The following is a description of a gene set: Human Gene Set: MIR6873_3P from publication Chen Y, Wang X (PMID 31504780) Genes predicted to be targets of miRBase v22 microRNA hsa-miR-6873-3p in miRDB v6.0 with MirTarget v4 prediction scores > 80 (high confidence targets). studied in species Homo sapiens, and this is the list of marker genes: CD160, ZNF91, GK5, NRN1 (neuritin 1), NPAT, PHF21A, ZNF439, SLAIN1 (SLAIN motif family member 1), RPP30, SEPTIN8, KCNK17, ZDHHC21, ZSCAN22, ZNF280B, SP100, ZNF268, MRO, ZNF676, SETD9, CTTNBP2NL, KRIT1, RIN2, ACSM2A, CBS, BTRC, MCM10, ZNF728, SRP19, PPRC1, SYNPO2, SOX5, CDC42BPA, SERTM1, SLC22A15, WBP1L (WW domain binding protein 1 like), SYS1, SORBS1, SLC25A20, VWC2, ADCYAP1, ATP2B2, RNF213, LRIG3, ZNF594, TLE5, GPATCH11, RNF169, ANOS1, ZNF778, PITPNM3, FBXL16, MAN2A1, IL5RA, STON2, DTNA, CD300E, SNRK, NLK, DCUN1D5, PDK3, ZNF100 (NCBI Gene Id 7653), CYTH4 (NCBI Gene Id 29776), ZNF708, ZNF302, BMAL1, ZNF195, SLC5A12, KCNK6, FAM131B, VCF1, POFUT1, RORA (NCBI Gene Id 6095), LYSMD3, VIP, CACNG8, ZNF559-ZNF177, ZNF107, PROM1, PPP6R1, B3GLCT, INHBB, ANTXR2, RREB1, DENND4A, ZNF426, TRMT12, METTL8, SMIM8, PDE7B, AUTS2, APBA1, USP32, ZNF761, ZNF468, ZNF544, VAT1L, KCNS1, EYA3, ZNF578, PGF, RABEP1, MAP4K2, SPOP, ZNF90, MBNL3, MAGI3, SHOX, HRH1, RPRD1A, RIMKLB, CTSO (NCBI Gene Id 1519), ZDHHC22, CDKN2AIP, PAPPA, ZNF716, CCDC178, PURA, EFCC1, MAFG, ZNF772, GPC6, ALKBH8, ATXN1, ASCL1, RDX, GRAMD1B, DPF3, LGSN, COPS2, ZNF596, GDAP1L1, ZBTB7A, ZNF701, RTKN2, VGLL3, ONECUT2, STAT5A, C11orf87, ZNF816, ARF6, ZNF208, CFAP97D1, GPBP1L1, POU2F2, TVP23C, TRPC5OS, MSI2, TBL1X, TAF11, DNAAF11, TMEM245, DPYD, HLA-DOA, PRPF38B, DENND6A, HOXC6, MAP3K2, LZIC, CNIH3 (NCBI Gene Id 149111), MAPK14, ZNF514, FASLG, TFAP2E, ZBTB17, IL17RA, MZT1, HMGCS2 (NCBI Gene Id 3158), SPRY3, ACER3, LONRF3, ZNF493, VANGL1, CDK12, WDR45B, NEIL2, ZBTB40, ARHGAP42, WWC1, MC2R, ZNF813, WSCD2, TMCO1, ADPRH, PPP2R5B, ZFP90, ADRB2, ACSM2B, WNT8A, GABRB1, APELA, SLC7A11, BHLHE22, LENG8, KIAA1549L, RBFOX2, MDM2, CPLX2, SBNO1, FAF2, PLCL1, ADRA1A, SMIM21, PLA2G7, LRRC10B, PSD3, CDH19, ELAVL3, SANBR, ILDR2, EMX2, PDGFA, PLXNA1, NELL1, CALU, RAPH1, ZNF711, AGAP1, RNF148, NHERF2, USP6NL, LACC1, SLC12A2, PRDM2, CARMIL1, MBNL1, HNMT, PRDM10, KIF4A, ZNF655, SNCA, SF1, ZNF135, TM9SF3, ARHGEF3, SIGLEC15, CCL16, PLEKHA6, ZNF28, MAP1B, SCN2B, NLGN4X, SYNJ2BP, CHMP7, TBC1D19, FANCC, REP15, MOB1B, USP10, PLGLB1, ZNRF3, ENPP1, ZNF611, PARD3B, ZNF99, EP300, HOXC5, PARM1, DDX19B, GPR161, THSD7B, PGM2L1, ELAVL4, NEURL1B, PAGR1, GPATCH2L, ZNF610, FRMD3, BBX, MSL1, TBX5, STK17A, SLC10A3, PCP4, SBF1, MID1, SLC5A3 (NCBI Gene Id 6526), KAZALD1, AQP4, ZNF117, KIF21A, OVOL2, SELENOS, CD86, DISC1, C22orf46P, MTPN, GLCE, WDR27, SOST, EVC, TLX2, CADM2, IFIT2, BNC2, PCSK4, ZNF138, ST8SIA1, POU3F2, ENSG00000274276, RNF185, TBL1XR1, SLC30A7, CC2D2B, MAFK, ARL15, ASAH2B, BCL11A, TMEM135, DES, GRID1, ESRRG, ZNF670, MYLK, ZNF844 (zinc finger protein 844), ZNF808, PEG10, ZNF124, CD44, NTRK2, SV2C, EPB41L3, MARK1, LPP, ZCCHC8, NIPA1, ZNF415, ZNF557 (NCBI Gene Id 79230), ZDHHC9, AGPAT1, RTN4RL1, IKBIP, TBX3, SGMS1, TNS1, SMARCA4, TNFRSF13B, GPR176, FRMPD4, KCNJ3, TLE4 (NCBI Gene Id 7091, TLE family member 4, transcriptional corepressor), HDAC8, ZNF562, MEX3A, RANBP3L, CELF4, SEMA3A, ZNF721, ZNF136, ITGA4, CDNF, UNC13A, TMEM178B, LSAMP, ZNF718, SLITRK4, LTN1, DMRT3, ZFHX2, CALHM5, HAO1, F7, IRX5, OCRL, ZNF765, ZNF317, SH3TC2, EEIG2, ZNF440, TRABD, SMTNL2, KRT26, MYORG, TUT4, ZNF730, PTPN4, GUCY1A2, ZNF816-ZNF321P, NAMPT, ZNF763, SH3PXD2A, NUAK1, YPEL5